The following is a description of a gene set: Human Gene Set: MIR12135 Genes predicted to be targets of miRBase v22 microRNA hsa-miR-12135 in miRDB v6.0 with MirTarget v4 prediction scores > 80 (high confidence targets). studied in species Homo sapiens from publication Chen Y, Wang X (PMID 31504780), and this is the list of marker genes: ZEB2, PIAS2, FBXL2, GPM6A (NCBI Gene Id 2823), CPD, CALU, TGFBRAP1, TMEM119, MBTD1, GLYR1, TXNDC17, LPP, ZNF709, SPAM1, ZNF805, TMEM167B, AP4E1, CCNE2, PSD3, RIOX1, PLAGL1, MRPS23, TBRG4, ANP32E, ZDHHC2, EXOC5, STAM2, CTBP2, HRH4, PPP1R3C, ZNF91, ZMYND11, EIF5A2, WAC, SP4, ADRA1A, GPC6, KRTAP13-1, TMEM170B, ZC3H12D, PDZD2, CXXC5, CAMK1D, PRLR, PPP1R1C, NELFE, ZNF214, EXOSC3 (NCBI Gene Id 51010), TADA1 (NCBI Gene Id 117143), SS18, KLF12, OLIG3, SEPTIN2, GRB10, MYO6, IRF2BP2, MTG1, C8orf58 (chromosome 8 open reading frame 58), EVI2A, RNF111, LMNTD1, CLTC, COL24A1, KRBOX4, PREX2, ZNF516, SLC25A26, BTBD3, TBC1D14, DNAH5, MMAB, LSAMP, ADH7, ASB7, CSNK1G3, B3GNT5, DICER1, CEACAM7, PM20D2, RNF6, PAX5, FOXJ1, ZBTB20, PPP1R8, WIF1, SLC1A2, YTHDF3, UST (uronyl 2-sulfotransferase), ESYT2, MGME1, ELP5, PRIM2, BICD2, NCOA2, UBXN7 (NCBI Gene Id 26043), KIAA1143, TOR1B, PTPN2, SYNJ1, CDKN2AIP, CD300LF, MTMR7, RAD51AP1, SETD9, ZBTB1, AHSA2P, INTS6, SPP1, GSPT1, RCN2, MIER1, VPS37A, ADGRF3, DCK, RORA, MAGI1, CEMIP2, ZMYM1, CA12, MTMR10, SEC63, FAIM, GLRA3, RBM44, RBM3, CAP1, TDRKH, YLPM1, ROBO1, TBR1, QKI, PTPN14, HAX1, CCDC186, GJA3, THUMPD2, TMEM65, ZNF189, THSD7B, MATR3, DPY19L1, IGF1, PKMYT1, EHD4, ZNF626, IPO9, ZNF681, ST6GAL2, PRKAB2, TBCA, ADAM10, TMPO, MFSD6, COLEC10, RIDA, ESRRA, FGF2, SLC33A1, DHX35, DOCK5, FSTL5, ZNF267, OSBPL6, TLN2, ZNF704, CAMK2G, WDFY3, TRDN, FAM168B, UNC5B, C1orf52, GABRG2, CWF19L1, RHOBTB3, BSDC1, RBM23, EIF1AD, CTDSPL2, SORT1 (sortilin 1), SPRY2, CAMSAP2, ATRN, CDK13, ZNF135, ANKRD42 (NCBI Gene Id 732033), GPRC5B, PIGN, CHL1, NEFL, NUDT4, RABGAP1, PLA2G12A, HSF2BP, CDK5R1 (NCBI Gene Id 8851)